Given this list of marker genes AHSG, PDE7A, KANK1, FAM161B, SEPTIN2, HIF1AN, ESYT2, RIMS3 (NCBI Gene Id 9783), KPNA4, ROBO2, TAOK3, SH3BGR, ARHGAP28, UBE3C, GATAD2A, GNPDA1, TMEM64, SERPINA1, PEX13, ACCS, CYBC1, IRGQ, PCSK7, SCN2A, HEY2, UBFD1, IGDCC4 (immunoglobulin superfamily DCC subclass member 4), LRCH2, KANSL1, MYO18A, KIF16B, HNF4G, ZFYVE16, CDC20B, SEH1L, NWD1, TDRP, MINDY2, SLAIN1, MAP2, PLXNC1, ATG4A, KCNIP1, JARID2, UBL3, BRWD1, GPCPD1, UHRF2, SERPINI2, E2F3, TRIM9, GRIN2A, ALDH1L2, QRICH1, PHF21A, PAFAH1B1, SPINT3, OTUD7A, SUCLG1, MYPOP, KIF21B, CLCN3, MLEC, ATXN7, RAB8A, SV2B, BTK, ADCY3, GET1-SH3BGR, TUSC1, ZEB2, DNMBP, SNX30 (NCBI Gene Id 401548), VWA5B2, SCN4B, NMNAT2, MAPKAPK3, MTCL1, CREB1, LANCL2, WDFY3, EIF5B, MGAT4B, CSMD2, U2SURP, XYLT2, NAA20, LMNA, SLC44A1, UBTD2 (NCBI Gene Id 92181), GAREM1, ERF, TMA7, AKAP6, PRX, ZNF585A, SIPA1L2, AFG2B, GPR63, MYORG, PRKAR2A, ESR1, TRPS1 (NCBI Gene Id 7227), REEP3, FBXL18, PPP4R2, ZEB1, CEP164, CACNA1B, ZNF436, SCN3A, GRK2, MIDEAS, RGS7BP, OSBPL11, PTK7 (protein tyrosine kinase 7 (inactive)), RPL7L1 (NCBI Gene Id 285855), POLE3, HIPK3, SMARCD1, ZFAND5 (NCBI Gene Id 7763), BTBD7, FASLG, FAT1, ANKS6 (NCBI Gene Id 445575), SLC39A10, APPL2, RSBN1L, GIT2, EIF4H, SDC3, STK39, UBE2K, DOCK11 (dedicator of cytokinesis 11), TMEM214 (NCBI Gene Id 54867), SORT1, LMAN2L, RHOB, MORC2, PPIF, ARAF, PPM1B, RNF123, SENP8, KCTD6, MAGI1, KRTAP26-1, PGAP1, LDLR, TENT5A, TFDP1, CSDE1, DSG1, ZDHHC17, TLN1, CAV1, KCND3, GNB4, ZBTB22, PLEKHA1, FAM167A, CTTNBP2NL, CTNNB1, CAST, TIMP3, ZNF688, BCL7A, FOXO1, ACVR1B, CKS2 (CDC28 protein kinase regulatory subunit 2), SKI, ETF1, PFN2, DNM2 (NCBI Gene Id 338330), RFX3, KCNMB1 (NCBI Gene Id 3779), USP12, TMEM248, FZD1, SOX8, RMND5A, CRBN, APP, WNT8A, TOGARAM1, NPLOC4, RAD21, ZNF608, MTSS1, TEAD1, RBPJ, CREB5, KCNH8, DVL2, SPRED2, THY1, CREBZF, SRPRA, ERGIC2 (ERGIC and golgi 2), LMAN1, PDGFB, ARK2C, ABLIM3, MED28, CYB561D1, HOXD1, TSHZ2, MEOX2, here is a description of the gene set: species: Homo sapiens Human Gene Set: MIR4269 Genes predicted to be targets of miRBase v22 microRNA hsa-miR-4269 in miRDB v6.0 with MirTarget v4 prediction scores > 80 (high confidence targets). from publication Chen Y, Wang X (PMID 31504780)